The following is a description of a gene set: Genes down-regulated in CD8 T cells stimulated by IFNA2 versus those activated by anti-CD3 and anti-CD28. Human Gene Set: GSE17301_IFNA2_VS_IFNA2_AND_ACD3_ACD28_STIM_CD8_TCELL_DN studied in species Homo sapiens IFN alpha mediated gene expression pattern. The effect of IFN alpha on human CD8 T cells responding to antigen (signal 1) and costimulatory signals (signal 2) provided by beads coated with anti-CD3 and anti-CD28 mAbs. This analysis examined the effects of IFN alpha on human CD8 T cells responding to antigen (signal 1) and costimulatory signals (signal 2) provided by beads coated with anti-CD3 and anti-CD28 mAbs. Magnetically sorted untouched CD8+CD45R0- T cells from three different donors were unstimulated or stimulated with IFNa2b or with anti-CD3/CD28 Beads alone or along with IFNa2b or IFNa5 for 48 hours. Individual mRNA samples were analyzed using HG-U133A 2.0 array gene chips. from publication Hervas-Stubbs S, Riezu-Boj JI, Gonzalez I, Mancheño U, Dubrot J, Azpilicueta A, Gabari I, Palazon A, Aranguren A, Ruiz J, Prieto J, Larrea E, Melero I (PMID 21108462), and this is the list of marker genes: SMCO4, DNAH6, CLPB, MSRB2, ZNF195, DPYD, GNA15, SLC20A2, ANKRD55, ZNF215, INSL6, CENPU, FHIT, NEK7, GAPDH, RASA1, PTGIR (NCBI Gene Id 5739), EIF4G3, PDE8B, SOX2, ME3, TRAT1, TNFSF10, GFRA1, CDCP1, STK32B, CD83, CHST7, RIN3, SRGAP3, LGALS9, FLNB, MLEC, ARF6, CHRM5, GRB10, GRSF1, FGGY, QPCT, PLCL1 (NCBI Gene Id 5334), SOCS2, PSORS1C2, STK39, RYR1, SMAD3, CLDN1, HES1, IL1R2 (NCBI Gene Id 7850), SLC19A2, OAS1, NXT2, GLS2, TIMP4, TREM1, GRK5, PBK, CREG1, KLF3-AS1, JADE3 (jade family PHD finger 3), CENPI, RAB14, CBFA2T3, PRKN, SPATS2L, RAB32, SERPINE2, ITM2A, NEK3, TUB, TPM2, TRIB1, GPHN, SLC31A1, OPN1SW, DEFA6, PRKCA, HTR2B, SCP2, TNFSF11, RCBTB2, JHY, ADGRL2, ATP2B4, YES1, HERC5, LGR5, BIRC3, FYB1, PGAP3, LY86, ELK3, IER3, ERLIN1, CNNM2 (NCBI Gene Id 54805), GRM3, DHX15, PTGS2, EPB41L3, SEMA3C, PLK3, NET1, GNA14, ICA1, PFKL, RNASE6, CA2, ZNF821, IFT52, FAM224A, NPL, RPL7, MXI1 (MAX interactor 1, dimerization protein), CYB561, NFRKB, MAGEH1, FBXO34, ADARB1 (adenosine deaminase RNA specific B1), IL4R, NFATC1, FDXR, WIF1, RIMBP2, ESPL1, MCC, REEP1, ADI1, USP15, CSTB, CA7 (NCBI Gene Id 766), SPRY4, MSRA, NCF4, SEC24D, CRIP1, MAP4K4, PLSCR1, APOO, TUBA1B, GPR183, MINDY1, NTRK2, TMOD2, MMP9, LRRC75B, PTPRM, IL21, CLCA3P, RAPGEFL1, GINS2, STAU1, IL6R, NDST3, GAL3ST4, ADAM23, GNAI1, TPD52, HPGD, NFKBIA, DIRAS2, EID1, CNTNAP3B, STAT5A, FAM174B, CALM3, TNFRSF4, S100A11, EPS8L1, IL15RA, PLIN2, ADCY10, GCK (NCBI Gene Id 2645), RBMS3, EPHA2, CACNB3, TRAV8-3, PLEK2, SP110, CYP1B1, SNX1, ADPRM, KANK1, GPA33, MPP1, TUFT1, ALLC, RSAD2, FKBP10, EXD2, ECHDC2, KBTBD11, DAO, IL36G, VCL (NCBI Gene Id 7414), FBXL2, TIMELESS, DDR2, KIF3C, EFNA3, ADD3